The following is a description of a gene set: species: Homo sapiens Human Gene Set: HP_RECURRENT_SHINGLES Recurrent shingles Repeated episodes of a localized, painful cutaneous eruption related to reactivation of varicella zoster virus (VZV) and characterized by a characteristic rash in one or two adjacent dermatomes., and this is the list of marker genes: TAPBP, IGKC, POLD1, IGHG2, UNC119